The following is a description of a gene set: studied in species Homo sapiens from publication Chen Y, Wang X (PMID 31504780) Human Gene Set: MIR1286 Genes predicted to be targets of miRBase v22 microRNA hsa-miR-1286 in miRDB v6.0 with MirTarget v4 prediction scores > 80 (high confidence targets)., and this is the list of marker genes: DEK, SDR39U1, SIPA1L1, FBXO41, RORB, MAFB, DRC1, LARP1, GAS7, ABHD16A, PPME1, UBQLN1, SEC24C, PURB, RASSF5, STK16, SLC39A10, DIRAS1, SF3A1, BCAP29, TSPAN11, FBXO11, CD8B, LETMD1, PITPNM3, ARAP2, ATXN1, NEK9, IPCEF1, ABL2, JADE2, IGSF9B, SSH1, PITPNB (phosphatidylinositol transfer protein beta), ACIN1, PCSK6, KDM6B, CHIA, ATP8B2, SON, ZNF562, DDX11, NXNL2, WNT1, STOML1, USP42, CHST5, TAF5L, GDF2, BACH2, MAP1B, MTCL2, PCDH17, RAB5B, HNRNPK, CHIC1, NCS1, NFAT5, ZDHHC15, PLIN5, ZNF423, PHYHIP, CDC42BPB, CFAP43, ASPH, MAGEC2, MICAL2, ENTPD5, CD47, ARHGEF3, DYNAP (dynactin associated protein), LINC03043, DGKI, SLC24A4, ALPK1, CAMKK1, ZMYM5, SLC35A4, MMP16, PLXNA4, OPN5 (NCBI Gene Id 221391), RAB14, KLF12, VDAC3, MYD88, NDE1, HIF1AN